Given this list of marker genes PROSER3, SKAP2, IQGAP1, GABRA5, PPP3CA, VEGFB, PCNX1, METTL15, SETD6, IQCH-AS1, AKAP9, ZNF141, CDK19, VARS1, GAPVD1, ISG20L2 (NCBI Gene Id 81875), PIP5K1C, SRF, SLC38A2, USE1, SMARCC1, CCNY, ANGPTL4, DUT, FBXO45, POLR2G, ABCD3, CACNA1D, TMEM134, INPP5A, ST6GAL1, REEP3, MBTD1, CCDC18, KISS1R, MEX3B, SCP2, SDHD, RPLP1, PLEKHA8, ESYT1, GALNT2, GTF3A, ARHGAP35, TRIB3, OXA1L, ANKRD6, FRMD4B, TSPO, P2RX7, LINC00622, ARL4A, PMEPA1, MARCO, ATAD2, BTBD7, HS3ST1, ZMYND8, SLC25A3, TSPYL1, FILIP1L, TAF9B, CDC23, NCAPD2, BIRC6, MTA1, CARS2, ABCA17P, C8orf58, RALGAPB, MDGA2 (NCBI Gene Id 161357), TMBIM6, THOC6, LTB (NCBI Gene Id 4050), CYB5B, RPS13, SMARCA2, GGCT, FBXO3, P4HA1, LINC00630, EEF1B2 (eukaryotic translation elongation factor 1 beta 2), SORT1, CENPT, GANAB, KLHL36, MTREX, RNF125, HLA-F-AS1, HSPA9, SH3YL1, ARAP3, EPRS1, NETO2, SEC14L1P1, CUX1 (cut like homeobox 1), WDR3, PRKDC, DNAJC3, NUDT4, PIGT, NDUFB8, PRPF38B, MRTFB, HSF2, KCTD20, TMEM273, ERMP1, ZNF397, UGDH, SCFD2, TULP4, AP4S1, RPS4X, ZNF329, TPT1P8, RDH10, TBL1XR1, TBC1D22A, ARHGAP32, ABCE1, PDSS2, ABCA6, RPL8, PUM2, INTS4, BCLAF1, AIFM1, TTC19, RPS3, POLE4, INSC, RPL31 (ribosomal protein L31), B4GALT3, IARS2, TMEM126A, CCNB1IP1 (NCBI Gene Id 57820), IGF1R, NACA, ZSCAN2, MACF1, FH, FOXR2, ERMARD, NMT2, TSEN2, RPS14, GOLGA8H, ENSG00000215022, MIR99AHG, ZNF704, EDC3, RPL27, C6orf136, C11orf54, ZMIZ1, SCAI, VPS13B, ETF1 (NCBI Gene Id 9190), RBAK, SH3BP2, NOL9, SLC39A14, GOLGA3, PLEKHB2, SUN1, ATXN1, CD109, VCL, GFM1, MATK, PYROXD2, TTC3, MLEC, NAGA, DNAJB5, VGLL4, D2HGDH, TMEM243, RPLP2, TEP1, RCAN1, PJA1, UBE2J1, TSC1, RCBTB2, ILF3 (NCBI Gene Id 54783), ENC1, SPCS3, TTC17, ZNF558, TCERG1, FAM171B, ASIC5, here is a description of the gene set: Human Gene Set: GSE16385_IL4_VS_ROSIGLITAZONE_STIM_MACROPHAGE_UP species: Homo sapiens Human CD14 positive monocytes were purified from healthy volunteers’ blood and cultured in vitro for 4, 12, 24, 72 hours. While culturing, macrophages were activated alternatively with interleukin-4 (IL-4 100 ng/ml) or classically with interferon-gamma (IFNg 100 ng/ml)+tumor necrosis factor (TNF 50 ng/ml) or left without activation. Simultaneously, macrophages were also treated with vehicle (DMSO:ethanol) or 1mM synthetic PPARg agonist, Rosiglitazone. We used Affymetrix microarrays (U133Plus 2.0) to analyze activation and PPARg-induced gene expression changes. from publication Szanto A, Balint BL, Nagy ZS, Barta E, Dezso B, Pap A, Szeles L, Poliska S, Oros M, Evans RM, Barak Y, Schwabe J, Nagy L (PMID 21093321) Genes up-regulated in macrophages (12h): IL4 versus rosiglitazone.